The following is a description of a gene set: Mouse Gene Set: GM6871_TARGET_GENES from publication Yevshin I, Sharipov R, Kolmykov S, Kondrakhin Y, Kolpakov F (PMID 30445619) species: Mus musculus, and this is the list of marker genes: 5330411J11Rik, Dlg5, 0610039K10Rik, Idi1-ps2, Ccl25, Agpat4, Gm8918